The following is a description of a gene set: Human Gene Set: ELF2_TARGET_GENES from publication Yevshin I, Sharipov R, Kolmykov S, Kondrakhin Y, Kolpakov F (PMID 30445619) species: Homo sapiens Genes containing one or more binding sites for (ELF2) in their promoter regions (TSS -1000,+100 bp) as identified by GTRD version 20.06 ChIP-seq harmonization., and this is the list of marker genes: CLPTM1, RAD51AP1, TSGA10, MYO1A, SAC3D1, RBM34, COPS7A, MAN1B1-DT, ZSWIM3, CTU1, MPC1, LSM8, SPATA17, HSPBP1, SND1-DT, SLC35A3, COX8A, MTMR9, KLRG1, LAPTM4A-DT, ARMT1, ZNF468, GNPTG, ARL16, CCNDBP1 (NCBI Gene Id 51718), CIRBP, ERVK3-1, SETD4, HIGD2A, UQCC1, MBD3L1, CHMP1A, RNF115, CD2BP2-DT, TRAFD1, RPS18, CBLL1-AS1, GID8, ACLY, FBXO8, SDHAF2, SENP1, CNBD2, MIR4727, DIS3 (DIS3 homolog, exosome endoribonuclease and 3'-5' exoribonuclease), RNF25, CCAR2, NUP214, RPS19 (ribosomal protein S19), PDCD6P1, GBA1, FBXO45, MED15, GABPB2, SLC36A1, ZNF410, MAU2, TMED8, RPL32P3, TPRKB, RBM12, HMGB2, SNHG19, MRPS23, VPS25 (vacuolar protein sorting 25 homolog), MRPL46, DIAPH1-AS1, ARID3B, RNA5SP146, SMARCAD1-DT, BAG4, ZSCAN16, LAMTOR4, C1D, NEMP1, TUBA1B, ADPRHL1 (ADP-ribosylhydrolase like 1), CHCHD5, CDK10 (NCBI Gene Id 8558), TOMM6, SIGMAR1, CLHC1, MDH2 (malate dehydrogenase 2), TMEM9B-AS1, LIPE-AS1, TBC1D22A-DT, WWP2, M6PR, TMPOP2, URM1, ELAC2, PPP3R1, CCDC47, STK4, GTF2A1-AS1, PLOD3, NUP58, KIF9, UMAD1, ALDH1A2, CDK9 (NCBI Gene Id 1025), OSBP, METTL16, ADPGK, DELE1, PIPOX, DMAC2, ZNF44, MRPL27, OS9, CARD8, ZDHHC6, CHFR-DT, TUBA1B-AS1, FANCD2, WDR74, ATG13, MMUT, STK4-DT, SF3B5, ANKRD13A, PPIL1, ATXN2L, SNORA21, DENR, FDXACB1, FEN1, C1orf52, RPL22, EDEM2, EMC3, ISY1, MIR638, GARS1, ARK2N, VPS33A, MIR8059, BLOC1S5-TXNDC5, MIA3, ARID4A, ACOT8, UNC45A, TBC1D19, COQ9, VARS1, C12orf76, NASP, DDX11-AS1, DARS2, POLDIP2, PIGC, SBNO2, ISY1-RAB43, VTI1A, CDK11B, ZCRB1, RN7SL2, TXNDC17, MYL12A, XNDC1N, RXFP4, ATG12, RPA3, TTC23, PCED1A, RPF2, SRBD1, ATP6V1D, ZFAND4, USE1, NMRAL1, LRPPRC, MPLKIP, COX14, ZNF473, PSMD13, RN7SKP175, BTF3L4, C1orf131, DCAF6, ZNF26, RRP15, POP5 (NCBI Gene Id 51367), THEM4, HEMK1, CDC40, SCAMP3, TMED2, SPATA33, WDR83, FAM216A, RRP12, NSUN5, APTX, STYXL1, ARFIP2, GTF3C2-AS2, ARPC4-TTLL3, EIF5A, VPS8, DR1, HIKESHI, CKS1B, ZSCAN5A-AS1, PRMT3, AAGAB, FRG1, VPS39-DT, FIG4, LINC01635, C19orf44, ATP6V1H (NCBI Gene Id 51606), PRCP, ACBD3, IRF2BP2, LARS1 (NCBI Gene Id 56885), NBR1, SLC39A9, CIDECP1, CUTA, PRMT7, ZNF689, VPS52, SCP2, PSMF1, SLC35A4, NAA35, DEDD, PPP1R11, EEF1B2, PIDD1, DDX56, TRIAP1, CHCHD2, CYBC1, DDX11, ZNF180, CHFR, NELFB, UBE4A, MTFR2, TMEM208, ZNF747-DT, BRMS1, VPS33B-DT, C6orf62, SIRT7, SRGAP3, SGO2, ULK4, SMG7-AS1, STIL, ZNF232-AS1, TCTA, NFKBIB, KIFC3, ZNF524, EBLN3P, CCNI, C1orf43, CEP192, UGGT1, PPP6R1, ZNF333, NDUFAF7, CDKL3, FBRS, MAPDA, UQCRC2, ARHGEF18, BCL2L1, LCMT1, UBXN8, KYAT1, PEX12, LAPTM4A, NUDT5, SNX1, BNIP1, AHCYL2, DLGAP5, HARBI1, NR3C1, EIF3I, ELP3, ERLIN2, RPN2, UBR1, CAGE1, SLC35F5 (solute carrier family 35 member F5), PHF12, CENPL, SEC23IP, LIPT1, GTF2H3, TAGAP-AS1, TMEM94, NUDT13, ZDHHC12, GTPBP4, ZFYVE1, SGO1, LINC00467, SCRN3, XPC, EIF6, RAB2B, CENPP, KAT7, TMEM9B, PSMA4, AFG1L, UXT (ubiquitously expressed prefoldin like chaperone), ANKRD24, MRPS18A, KIF14, SLC25A26, COX15, POU2AF1, ACBD5, KRT10-AS1, COIL, AP3D1, ELK4 (NCBI Gene Id 2005), BUD31, ZNF558, HELB, SYS1-DBNDD2, MYL12-AS1, GSPT1, ANO6, ZSCAN5A, MCTS1 (MCTS1 re-initiation and release factor), LRRC28, PARK7 (Parkinsonism associated deglycase), GTF3C1, ESYT1, COP1-DT, ZSWIM8, DBP, SF3B2, ENSG00000248636, SPNS1, INO80, LRRC8A, FBXO9, TOP3B, PIGO-AS1, CIAO2B, TMEM199, AP1M2, USPL1, CNTD1, ZNF654, CEP164, RBM45, VPS4B, SPA17, INO80B-WBP1, SAMD15, BBIP1, UBXN6, PGAP4, BANF1, FBXL9P, AIMP1, STAM2, EIF2AK3, TBC1D2, RNASEH1-DT, PPCS, CDKN2C (cyclin dependent kinase inhibitor 2C), PRKAB1, EEF1AKMT3, C19orf25, PPIP5K2, OXNAD1, SEPTIN1, AP5Z1, FKBP1A, STX16, NOL12, YJU2, POLR2M, DDIAS, AP3S1, TEFM, GTF2A1, TRIP4, SP100, SH2D3A, NOB1, THAP11, SIRT3, ZFP28, TMBIM6, ZFPL1, METTL6, PFDN6, RPS25, TTF1, CNDP2, DGUOK, PUM3, FBXO46, PIBF1, BLOC1S1, POC5, CATSPERG (NCBI Gene Id 57828), DAZAP2, CEP70, MAPKAPK5-AS1, WDR5B-DT, APMAP, DYNC2I2, MEIS1, PRR12, SLC28A2-AS1, RPAP1, ZNF765, RBM42, BCL2L13, ZNF292, DNAJA3, ATP13A1, ZC3H3, CALR3, NDUFV3, RABGEF1, SEC11A, INHCAP, RPL13A, STK36, NAGK, SUGT1, LMAN2, TAF2, EXD1, FASTKD5, CENPT, GON7, EAF2, RPF1, RPS15, MRTO4, SUPT6H (NCBI Gene Id 6830), TSC22D4, DNLZ, HMOX2, CCDC38, RNU6ATAC, CDIPTOSP, AFG3L2, GOSR2, CIR1, SLC38A10, TRAF7, RPS29, TAF1C, CENPBD2P, NDUFS2, TMEM222, WDR46, RAB27A, E2F4, PTBP1, ALPK1, ZNF701, MIEN1, POLI, DEPDC5, POLG2, FAM83C-AS1, ATG5, RAPGEF6, RNASEK, MTRF1, TYW1B, ZUP1, FAM120B, JAGN1, AXDND1, SOCS4, THTPA, LAMTOR5-AS1, ALG10B, EMC1, HTRA2, PPP4C, ZBTB17, STX10, ELL, ZNF394, RHOA, SEC1P, FDPS, NUDT1, SLC7A6OS, YWHAE, CHP1 (NCBI Gene Id 11261), COX7A2, ANAPC5, ZFHX2, IPPK, ZDHHC7, CFAP20, AK9, SART1, FZR1, TMEM230, ACTR6, DIDO1, THAP9-AS1, STK40, UBE2S, FRS3, PRORP, BECN1, WDR24, UTP23, PLA2G6, DHODH, VPS16, ZKSCAN3, THG1L, NUP42, DDX5, TOX4, BORCS8-MEF2B, FOSB, TBL3, SYS1, DNAAF4-CCPG1, TFB2M, RPL30, WTAP, SFT2D3, TTI1, PES1, RPL34-DT, TMEM38A (NCBI Gene Id 79041), LRIF1, NOP53, RNF20, TMEM258 (NCBI Gene Id 746), TMEM184C, DYNLRB2-AS1, HMBS, FAM117A, IQCG, ZNF774, HPS5, FBXO38, SLBP, GTSE1, ZNHIT3, SCYL3, TIMM10B (translocase of inner mitochondrial membrane 10B), MUS81, RAB11B (NCBI Gene Id 9230), SEMA4B, CFAP68, ENO1-AS1 (NCBI Gene Id 100505975), NKIRAS1, CNST, USP36, GLYCTK, SRSF10, MXD1, KICS2 (NCBI Gene Id 144577), ARHGEF37, CD164, ADAP2, CIAPIN1, RPS27A, FBXO32, UBB, PSMB5 (proteasome 20S subunit beta 5), WFDC3, CCDC174, ATP5PF, NUFIP2, TAF7, NME7, THUMPD3, TRMT6, WDR3, WASF2, TOMM40, TAF12, MTIF2, GALT, FIZ1, ZNF787, IFT70B, ZNF845, PDAP1, IRGQ, UBXN4, ZNF611 (NCBI Gene Id 81856), PDE12, ZNF778-DT, DLL1, LRR1, CPNE1, MOCS3, LAMP1, PDCL3, ARHGAP12, B3GALT6, CDK7, SS18, POLR2B, ATF4, C11orf52, CD2BP2, LETMD1, YBEY, MRPS31, PIGBOS1, WRAP73, MYL12B, SLC25A38, PTCD3, KIF11, SEC31A, ERAP2, TRIP12, ANKRD17, PSMD14, GATB, CLP1, CCDC71, GABPA, SLC27A5, GTSE1-DT, DYNC2LI1, NTHL1 (nth like DNA glycosylase 1), SH3RF2, DXO, ANAPC10 (NCBI Gene Id 25866), ZNF747, TOMM70, ARPC3, MCM7, ZNF622, TTC5, CDNF, FBXW9, ANKHD1-EIF4EBP3, COMMD6, MED28-DT, VCPIP1, NSL1, EIF2AK3-DT, MGME1, CDIN1, WDR45, DDX28, PROSER3, C22orf23, TM9SF1, CES2, TSSK6, SLC25A53, MRPS18B, MRPL30, PCM1, H4C16, RUVBL1, MCM3AP, TEPSIN, C18orf32, EVI5L, GAPDH, NOA1, RPL27A, GTPBP10, C4orf33, CHD8, UBOX5, EME1, PCBP1, ZPR1, TRIP11, WIPF2, ZNF576, DPM3, ZNF684, XRCC5, ZNF107, TAB3, RPS7 (NCBI Gene Id 6201), CHURC1-FNTB, NSUN3, DDX39B, ABT1, SDF4, ANKRD40CL (ANKRD40 C-terminal like), STK38L, SREBF2, NUP155, FBXO24, MAN1B1, NDC1, MCCC2, PTRH1, ZNF317, PDCD6-DT, ZNF48, RAB18, ZNHIT1, MEF2A, EXOC4 (exocyst complex component 4), FUZ (fuzzy planar cell polarity protein), SNORD60, NMNAT1, RPL38, PARS2, TPRN, EMC7, RCCD1, SFT2D1, MAPK7 (mitogen-activated protein kinase 7), TBCK, DPP3, AAK1, MRE11 (NCBI Gene Id 4361), SPRED2, CBLL1, NUP35, PPP1R37, DDX39A (NCBI Gene Id 95781), TERC (telomerase RNA component), SPAG7, AAR2, MPDU1-AS1, DHX37, CPSF7, RFPL2, SHMT2, TRAPPC10, AOPEP, CREBRF, DDX23, YWHAZ, ADIPOR2, ODF2, CEP120, MED19, RAB1A, SCNM1, VASP, TXNDC12, DHFR2, GTF3C2, RAB11B-AS1, RAD50, CHMP4A, UTP18, ZC3H10, C1orf220, ESR2, NUDCD3, CCDC97, SIRT6, TM2D1, LENG1, KLHDC4, USP11, PAIP2, ERH, CEP44, CSNK1G1, VRK3, CUTC, STK35, STAMBP, PPP2R5E, METTL1, B9D1, MCM6, MYO19, IFT70A, ATG16L1, ADSL, RFWD3, HECTD4, SUGP1 (SURP and G-patch domain containing 1), PCLAF, PPP2R3C, POLR2F, SNORD15A, SIRT2, RBL1, VEZF1, MIPEP, MALSU1, MFN1, TMEM59, ELF1, ANKHD1-DT (ANKHD1 divergent transcript), ZNF587B, MRPS7, PPP4R3B-DT, NKAPD1, INIP, ZNF688, GPN3, TM2D2, CACTIN, RAD51D, ZNF28, COMMD5, RABEP2, CTR9, MRM2, BMS1P4-AGAP5, COP1, PHKG2, ARRDC4 (arrestin domain containing 4), SMARCC2, PLPP6, PSMA3-AS1, WDR82, RPS3, GON4L, DDX49, FIRRM, SMARCAD1, EPN1, ENSG00000187951, SUGT1-DT, LIPE, NOSIP, CDK12, ENO1, HJV, HROB, COPE, UFC1, PGS1, OXLD1, ITPA, ZNF384, ATP13A4, RPL23, PIGW, SKIC2, RPL6, COASY, PFKM, ENSG00000187185, SRP19, MRPL44, MRPL33, LYSMD1, SHB, KLHL26, PMM2, THAP1, METTL18, SUPT16H, DERL1, MYBL1, SCAND2P (NCBI Gene Id 83038), SPHK2, TMX1, PEX16, MOB1A, MRPL51, CCDC18, DYNLRB2, SUGCT, ATP6V1E1, EXOSC3, RNPC3, COPB2-DT, CWF19L1, ZMAT2, FAF1, SNRPB2, TBC1D22A, NICN1, AIDA, RPIA, NVL, ZNF266, SNORD84 (small nucleolar RNA, C/D box 84), HMGB1 (high mobility group box 1), GPATCH2, PKP4, SSBP1, VPS35L, EFCAB6, TSG101, AKT1S1, EIF2B1 (NCBI Gene Id 1967), GPATCH4, RPS26, IQCH, FAM53C, DNTTIP1, MINDY3, C2CD2L, FDFT1, CDCA5, ZFP28-DT, PPP1R12C, NUBP1, GPATCH2L, MCRS1, LTN1, RPL18, NOL10, RPE, LINC02166 (NCBI Gene Id 105371416), ITGB3BP, TATDN3, INCENP, TIGD4, PNPLA4, GOLGA3, PRPF38B, UFD1, BROX, TMEM198B, TMEM183A, DNAAF4, VPS72, DHX33, KIF3B, RPRD1B, MFF-DT, ITGA7, PPIE, SPRTN, MROH8, NDUFS1, CEP89, PPHLN1, ACO2, ZNF217, TBRG4, NAA25, DUS2, NARS1, CCT5, CHMP4B, EFCAB7, MRPL10, COPS5, ARMH4, CGGBP1, UBQLN1, CRADD, TTC14-DT, HAUS8, RALBP1, GSK3A, VTA1, MAK16, UCA1-AS1, EOLA1, RSU1, HSPA9, ZNF277, VPS13B-DT, LRRC46, NLK, ADAT1, MINCR, FTSJ3, CIAO2A (NCBI Gene Id 84191), TMEM126A, NCAPD2, HSPB6, CCDC28A, CFAP52, GHDC, KBTBD2, PHF14 (PHD finger protein 14), SNRNP200, TMX2, CYB561D2, COPA, CLK3, STK11IP, PICK1 (protein interacting with PRKCA 1), GTF2H1, VAC14, COQ5, ZNF341-AS1, ATPSCKMT, ZKSCAN5, EIF1AD, SLC35A2, RPL29, G2E3, SND1, STK19, PSMA6, ZDHHC12-DT, IER2 (immediate early response 2), RMND1, DCLRE1C, ARHGEF18-AS1, LINC01315, ZNF580, DDX42, ERCC5, MYO9B, EXOC8, ADGRE3, HGS, APPL2, MFF, ZDHHC5, TADA3, GOLT1B, MED11, TMEM260, AATF, UTP3, HIBCH (3-hydroxyisobutyryl-CoA hydrolase), BORA, ANKRD42, CDC123, PRR13, PPP1R10, MAP3K5, LRCH4, EIF4E2, TEDC1, DDX21, WBP1L, SRRM5, MZF1, SGO1-AS1 (SGO1 antisense RNA 1), ENSG00000272008, PIGO, TIMM10, CAPN10, STX16-NPEPL1, NFIC, MCM3, C18orf21, DNAJC7, TM9SF4, NOL8, AIP, MLEC, IL5, ZBTB3, ARPC4, FDXR, TOR1A (NCBI Gene Id 1861), CFL1, SLC35C1, TFCP2, SMG7, RNF121, EIF2S1, GOSR2-DT, SCAND1, PCBP2, TTC14, GATC, ZNF731P, ENSG00000227218, ARMC5, TRAPPC6A, PIGT, IKBKB-DT, FIS1, OPA1, SCFD1, PNPO, DPH3, PIGB, CDC42SE1, RTF2, DMXL2, NFATC2IP, FERRY3, RPS19BP1, CSTF2, GIN1, FAAP24, CDK11A, TMEM234, RPL19, RNH1, PSME3, SNX5, WDHD1, RPL34 (NCBI Gene Id 6164), KDM5C, ZSCAN25, TGOLN2, KCTD10, GLUD1P3, MED28, ISG20L2, KTI12, PLK2, MBTD1, EIF3D, USP48, CLN3, CLPTM1L, LCMT1-AS1, RPL11, CARS1, NDUFA13, NCBP2AS2, UBR7, FBXW7, KIF23, RPS27, UBIAD1, ZNF837, GGA1 (golgi associated, gamma adaptin ear containing, ARF binding protein 1), PPIL4, NDUFB3, SNRNP35, LSM5 (NCBI Gene Id 95999), SIL1, TAP2, RNPC3-DT (RNPC3 divergent transcript), KATNIP, TMEM67, POLR2C, RPL7L1, DDX39B-AS1, ASB16-AS1, CSPP1, CABLES2, PCBP1-AS1, AP4M1, ARB2A, ARHGAP11B-DT, EXOC2, POLR1A (RNA polymerase I subunit A), CDIPT, KIF23-AS1, FLAD1, CENPQ, OTUB1, GIHCG, CEP152, NCSTN, RNF4, TCP11L2, KAT5, NUP205, HYCC2, WDR4, NOL6, MIR5787, LARP4B, SUPT4H1 (NCBI Gene Id 6827), ZKSCAN1, SHKBP1, CYB5R4, EMSY-DT, SEC24C (NCBI Gene Id 9632), INO80B, C10orf143, TCEANC2, EAF1, ANKRD11, NELFE, COX17, GORAB-AS1, ADAM9, SNF8 (SNF8 subunit of ESCRT-II), SCAMP2, SETD4-AS1, SMIM27, DHX40, RPL15, RPL37, CWC22, TBC1D17, RBSN, FARSA, COPG1, RECQL, DPM2, DDX19B, CCNG2, MUL1, CKS2, NFYC, RBBP4, C9orf72, CORO7, ZNF302, HSPH1, MRPS11, SART3, RAB7A (RAB7A, member RAS oncogene family), STX8, MIR6781, VPS53, MIR4999, CYCS, MITD1 (microtubule interacting and trafficking domain containing 1), RPS11, ZNF557, TAF12-DT, HIPK1-AS1, ZBTB45, WDR5B, GDAP2, ACAD10, EMSY, RPLP2, RASSF6, ATP8B1-AS1, RBM48, ENTPD1-AS1, NPRL2 (NPR2 like, GATOR1 complex subunit), TDG, TFIP11-DT, MFAP1, RIOK1, DDX18, DPAGT1, ZNF343, ANKRD49, EMC3-AS1, GOLPH3L, RBBP5, DPP9, SMARCAL1, COPB2, OXSR1, UVRAG, IKBKB (NCBI Gene Id 3551), PGGT1B (NCBI Gene Id 91374), MCMBP, COG3, SLC16A1, H2AX, SPATS2L, NUTM1, AP2B1, PSMD14-DT (PSMD14 divergent transcript), NSA2, DOCK4, BRAP, CWC25 (NCBI Gene Id 54883), BZW1, ING4 (NCBI Gene Id 51147), THADA, MOSPD3, CCDC148, GDAP1, KATNB1, GORAB, GNPAT, ARPC5L, PRP4K, NDUFAF8, STAG3L5P-PVRIG2P-PILRB, ZNF687, KLHL18, NHP2, SEC23B, SMUG1, METTL25B (NCBI Gene Id 51093), EEF1A1P23, ZNF628-DT, ZBTB8OS, WWOX (WW domain containing oxidoreductase), VPS51, ZNF490, SAV1, ZNF232, RPS14, TSR3, PGBD4 (piggyBac transposable element derived 4), RSPH3, RSL24D1, DBR1, TINAGL1, FRG1-DT, RPS17, PMS2P3, VPS39, CYP51A1, SRP54-AS1, GATAD1, RPL27, ZNF778, SLC52A3, CATSPERD, AP1S2, ATG101, SRP54, DNM2, CHURC1, SH2B1, NUDT18, GGA3, CCDC9, ANKRD42-DT, VPS13B, RNU4-1, THAP9, LONP1, SLC25A14, ZNF335 (NCBI Gene Id 63925), CHMP1B, SETDB1, SPG7, HPS1, VPS33B, EOLA1-DT, UBE3B, LZIC, TSC2, CEBPZ, NCBP2, GUCD1, TNPO3, DHX33-DT, SP2-AS1, EXOC1, HSPA14, KHDC4, TELO2, RNF181, GET3, STAG3L5P, RIN1, MATR3, SIK3, MIR4453HG, PIH1D2, SMIM7, LNP1, BLCAP, EMC4, ENSG00000260830, GMPPA, FBXO36, ZFC3H1, GLI4, SDF2, SPATA2 (NCBI Gene Id 9825), MPC2, DPM1, UQCC6, BRCA1, VPS45, BABAM1, CCDC137, PRPF40B, MBD1, LACTB, TPI1P2, LRRC41, CSNK1A1, MYL6B, SLC33A1, KNL1, TIGD1, BSCL2, SNRNP27, RFXANK, TRUB1, SYT11, U2AF2, NOP10, LINC00339, MON1B, ZNF460, MTF1, SHC1, PEX1 (NCBI Gene Id 7788), ZNF267, AKIRIN2, THAP2, TTC16, ANKRD17-DT, KIAA0753, SNRPD3, MYG1, AGAP2-AS1, IQCB1, ZNF791, EIPR1, SIAE, NR6A1, HBP1, C15orf62, BLOC1S3, RAB5C, GARS1-DT, PTPN11, TBC1D23, ELOF1, TANK-AS1, MTIF3 (mitochondrial translational initiation factor 3), APBB3, ABCE1, PDCD6, CLASRP, VPS41, COX16, SH3D19, UBQLN1-AS1, HIPK1, BLOC1S5, CCDC28A-AS1, MAPKAPK5, RNASEK-C17orf49, LCMT2, CRB3 (NCBI Gene Id 92359), EFCAB6-DT, TMEM184C-DT, RHOQP1, TRAPPC4, TRAIP (NCBI Gene Id 10293), TMEM160, LINC02569, VPS50, UBAP2L, TMUB2, WDR83OS (NCBI Gene Id 51398), FADS2, CEP95, LAMTOR5, AQR, FSIP1, BLZF1, PHF23, RN7SL832P, MZT1, CCDC7, ZNF627, CETN3, PSMA5, ZNF169, PRR14, BIN3, ZFAND3, LMLN, FBXO38-DT, CDC45, TMEM128, EIF3H, GFM2, BAZ2A, AUP1, STK10, UQCRH, GABARAP, ZMYND12, MCM8, MRPL54, LSM1, TFIP11, CCZ1P1, SNIP1, WEE2-AS1, ANXA4, NOL11, WDR55, MRM1, AMDHD1, PPP4R3B, ENSG00000282936, CLTA, NOP16, TAF11, MAP3K7, RPL32, COA3, KRT10, TMEM186, SEC16B, NCLN, WASF1 (WASP family member 1), CCDC61, TYW1, BORCS8, ARFIP1, SAR1B, ZNF581, RNASEH1, PIK3C3, LIN37, DNAJC14, DPP3-DT, SHOC2, POLR3C, LYRM2, UBXN1, PRSS16, DHX16, CCDC18-AS1, DIAPH1, PHF5A, AP2A1, PSMC5, HMGCR, ANKHD1